The following is a description of a gene set: Human Gene Set: GSE40274_FOXP3_VS_FOXP3_AND_SATB1_TRANSDUCED_ACTIVATED_CD4_TCELL_UP species: Homo sapiens Genes up-regulated in CD4 T conv over-expressing: FOXP3 versus SATB1 and FOXP3. The transcription factor FoxP3 partakes dominantly in the specification and function of FoxP3+ CD4+ T regulatory cells (Tregs), but is neither strictly necessary nor sufficient to determine the characteristic Treg transcriptional signature. Computational network inference and experimental testing assessed the contribution of several other transcription factors (TFs). Enforced expression of Helios or Xbp1 elicited specific signatures, but Eos, Irf4, Satb1, Lef1 and Gata1 elicited exactly the same outcome, synergizing with FoxP3 to activate most of the Treg signature, including key TFs, and enhancing FoxP3 occupancy at its genomic targets. Conversely, the Treg signature was robust to inactivation of any single cofactor. A redundant genetic switch thus locks-in the Treg phenotype, a model which accounts for several aspects of Treg physiology, differentiation and stability. from publication Fu W, Ergun A, Lu T, Hill JA, Haxhinasto S, Fassett MS, Gazit R, Adoro S, Glimcher L, Chan S, Kastner P, Rossi D, Collins JJ, Mathis D, Benoist C (PMID 22961053), and this is the list of marker genes: CDK18, PKD2L1, MCUB, ATP2C2, RANBP3L, SLC10A4, ACOX2, ZBTB16, SLC40A1, PROK2, ACKR1, TLL1, MTFR2, XIST, CDCA3, ID2 (inhibitor of DNA binding 2), GCDH, DIXDC1, ADAMTS3, NHS, PRSS46P, CCDC121, CDKN2A, DNAJC28, MIR379, ZPBP, APC2 (NCBI Gene Id 10297), ADAM7, MYADML2, KIF14, LDLRAD1 (low density lipoprotein receptor class A domain containing 1, NCBI Gene Id 388633), SYNPO, MAPK13, HOMER2, NEBL, CLCA4, PHACTR2, H2AC15, SCNN1B, SDC2, CCNA2, C1QC, CIT, ADAMDEC1, PLLP, MFSD4B, MIR32, LMX1A, IGDCC4, CDH24, RBP4, ZBBX, ADAMTS1, TNS1, ACTL6B, KCNA4 (NCBI Gene Id 3740), SCEL, FAM186B, FGF12, SEMA4G, IQCF1, COQ10B, FOXR2, TLL2, MIR377, CDCA5, HMGN2, CDCA2, P2RX7, S1PR5, SPACA6 (NCBI Gene Id 730718), TAGLN3, ENTPD1, CX3CR1, PRKAR2B, COLEC12, CXCL5, TSGA10IP, RNF151, GPNMB, MYF5, MIR490, COL9A1, KCNE1, SLC16A3, LPCAT1, MST1R, OGFRL1, MARCHF3, KCNC4, SCHIP1, AIPL1, GPR179, PLPPR3, LRIG3, CENPF, PCDH12, CCDC18, PPP1R1C, CENPS (centromere protein S), KLK13, GATA4, RNF144A, KCNG2, APOC4, RASL11A, MIA, SLC45A1, PTGES, SMCP, NPL, SGO2, C2CD4C, DISP2, TIMP4, HBEGF, NIBAN2, RHCG, IL1F10, FGR, SNCB, C1QA, C11orf87, THSD7A, MIP, KCNH8, CGA, SEMA5A, CBX2, DBH, FAM83E (NCBI Gene Id 54854), TEKTL1, EEF1G, CUL7, IGFBP6